Given this list of marker genes Acod1, Nod2, Il17f, Ivl, Pgc, Ppp2r3c, Ppl, Klk7, Klk5, Evpl, Il17a, Gata6, here is a description of the gene set: Mouse Gene Set: GOBP_REGULATION_OF_ANTIMICROBIAL_HUMORAL_RESPONSE Any process that modulates the frequency, rate, or extent of an antimicrobial humoral response. species: Mus musculus